Given this list of marker genes CRISPLD2, TPPP3, ZHX2, NOTCH3, PLXDC1, ADCY5, LMOD1, FGF13, INPP4B, ITGA11, PDGFA, EBF1, HEYL, MOCS1, RAP2A, SPON2, LTBP2, COX4I2, B3GNT2, MYH11, MAP3K7CL, KIAA0040, NEURL1B, PDE3A, HES4, MAP2, REM1, FST, ITGA7, CAP2, CNNM2, HRH2, COL26A1, PLCE1, DGKG, DGKZ, SH2D3C, KRT18, JAG1, NTN4, RERG, BTBD3, MEGF6, HOXB-AS1, TRIB2, ARID5A, MEF2C, PLEKHG3, ITGA4, TINAGL1, BCAR3, TM4SF1, CNTN4, PEG3, ABTB1, ARHGAP15, NPR3, KCNJ8, FILIP1L, CRIP1, PDLIM3, RIPOR2 (RHO family interacting cell polarization regulator 2), FRZB (frizzled related protein), GPX3, NIBAN1, KCNS3, SYTL2, ARHGAP29, LGI4, OLFML2B, ESAM, GJA4, SERPINI1, SEPTIN4, CCDC102B, PGM5P3-AS1, LRRC32, HSPA2, GEM, RFTN1, GAS6, CAV2, SEMA5B, SEMA5A, HEY2, ADGRF5, LUZP2, MCAM, MGLL, MRGPRF, DBNDD2, WFDC1, RCSD1, OLFM2, PDLIM5, NAB1, GPR183, ABCC9, TTYH1, ARHGDIB, NBEA, NRGN, MARK1, TRPC6, COL18A1 (NCBI Gene Id 80781), LASP1NB, EPAS1, HIGD1B, GATM, ENTPD1, PAPPA, MLLT3, ALCAM, ADGRL3, NTRK3, FOXS1, PRELP, RASL11A, CDH6, MCTP2 (multiple C2 and transmembrane domain containing 2), PERP, GRP, SGCA, RRAD, here is a description of the gene set: studied in species Homo sapiens Vascular SMC 1 Human Gene Set: HE_LIM_SUN_FETAL_LUNG_C0_VASCULAR_SMC_1_CELL from publication He P, Lim K, Sun D, Pett JP, Jeng Q, Polanski K, Dong Z, Bolt L, Richardson L, Mamanova L, Dabrowska M, Wilbrey-Clark A, Madissoon E, Tuong ZK, Dann E, Suo C, Goh I, Yoshida M, Nikolić MZ, Janes SM, He X, Barker RA, Teichmann SA, Marioni JC, Meyer KB, Rawlins EL (PMID 36493756)